Given this list of marker genes CYP19A1, ADAM12, KISS1, PSG7, LGALS13, PLAC4, HSD3B1, SLC16A4 (solute carrier family 16 member 4), VGLL1, PSG1, CRIM1, SVEP1, PSG6, PSG4, TFAP2A, EGFR, EGFL6, PAPPA2, CSH1, PAGE4, MAFF, FBN2, GCM1, LGALS14, PLAC1, PSG5 (pregnancy specific beta-1-glycoprotein 5), RHOBTB1, PSG3, IGFBP1, TAC3, CDKN1C, GH2, AOC1, EBI3, MAN1C1, INSL4, GDF15, CAPN6, MMP11, TIMP2, CRH, HSD17B1 (NCBI Gene Id 3292), SEMA3B, S100A10, ALPP, PAPPA, LEP, PSG9, PSG2, here is a description of the gene set: Neighborhood of KISS1 Neighborhood of KISS1 KiSS-1 metastasis-suppressor in the GNF2 expression compendium Human Gene Set: GNF2_KISS1 species: Homo sapiens